The following is a description of a gene set: Enables the transfer of carbohydrate derivative from one side of a membrane to the other. Human Gene Set: GOMF_CARBOHYDRATE_DERIVATIVE_TRANSMEMBRANE_TRANSPORTER_ACTIVITY studied in species Homo sapiens, and this is the list of marker genes: SLC28A1, SLC25A26, SLC35A1, SLC17A9, SLC29A1, SLC29A2, SLC17A5, SLC28A2, SLC37A2, SLC35D2, SLC25A42, SLC25A4, SLC25A17, ABCC5, SLC28A3, SLC29A4, SLC5A1, SLC5A2 (solute carrier family 5 member 2), LRRC8A, SLC25A31, SLC22A1 (solute carrier family 22 member 1), SLC25A5, SLC22A2, ANKH, SLC35B2, SLC50A1, SLC35A3, SLC25A41, SLC25A25, SLC35B1, SLC35A2, SLC46A2, SLC35B3, SLC35A4, SLC25A23, SLC35B4, TMEM241, SLC37A3, SLC19A1 (solute carrier family 19 member 1), SLC37A1, SLC35C1, MFSD2A, ABCC3, SLC35E3, SLC15A4, SLC37A4, SLC35D1, SLC25A24, SLC15A3 (NCBI Gene Id 51296), PANX1, SLC35D3 (solute carrier family 35 member D3), SLC25A6, SLC29A3, SLC35A5